Given this list of marker genes Cftr, Slc35d3, Nutf2, Ubr5, Ptpn22, Abcc8, Pmaip1, Erbb2, Gper1, Trpc1, Kif20b, Casr, Cep120, Dynll1, Cct4, Nlgn2, Fbxw7, Tmed10, Tek, Cd38, Tgfb2, Tgfb3 (transforming growth factor, beta 3), Ang2, Tomt, Atg7 (NCBI Gene Id 74244), Prkn, Ffar2, Gja1, Kcnn4, Osbp, Tmem132a, Cnst, Hnf1a (HNF1 homeobox A), Ppard, Sfn, Cdc42 (cell division cycle 42), Prkd1, Plk3, Rbm22, Ucn3, Golph3l, Hif1a, Emd, Cct2, Fto, Ice1 (interactor of little elongation complex ELL subunit 1), Adcy8, Commd1 (COMM domain containing 1), Adam9 (NCBI Gene Id 11502), Ptpn23, Il13, Glud1, Cd2ap, Prkaca, Exph5, Fga, Plcb1, Bag3, Fyn, Trh, Ghrl, Mmp13, Oaz2, Lep, Pfkfb2, Gsk3a, Tlr2, Doc2b, Pard6a, Ptbp1, Pcm1, Ipo5, Cdk5r1, Gck (NCBI Gene Id 14624), Oga, Trpa1, Vamp8, Dkc1, Sirt3, Cd81, Akap5, Nr1h4, Efcab7, Bad, Hras, Ppm1a, Snap25, Frmd4a, C2cd2l (NCBI Gene Id 71764), Pgrmc1, Camk2n1, Mcu, Pfkm, Nnat, Ran, Nutf2-ps1, Camk4, Vps28, Prkce, Bglap2, Glul, Itgam, Sh3glb1, Sec24a, Pak1, Glp1r, Vsnl1 (NCBI Gene Id 26950), Slc30a8, Atp2c1, Pdcd5, Tgfb1 (NCBI Gene Id 21803), Cask, Prpf4b, C1qtnf3, Mief1, Ifng (NCBI Gene Id 15978), Aacs, Coro2b (NCBI Gene Id 235431), Nkx6-1, Tcf7l2, Mief2, App, Prkcb, Acsl3, Ccl2, Sox4, Ptpn5, Isl1, Ang5, Chp1, Slc51b, Cct3, Or51e2, Myo1c, Lrrc8a, Gip, Dctn1, Rab29, Rab34, Orai1, Wls, Trpm2, Nr0b2, Pdcd5-ps, Hnrnpm, Apbb3, Anp32b, Tmem30a, Anxa7, Dnm1l, Mdm2, Rac1, Rufy3, Xpo4, Acsl4, Gpr27, Mavs, Gna11, C1qtnf12, Sybu, Ptger4, Atp13a2, Arpc2, Prkcq, Cct8, Edem2, Fgg, Hcfc1 (host cell factor C1), Arf1, Jup, Prkaa1, F2, Pcsk1, Serp1, Ywhae, Hyal2, Gpr68, Stom, Dmap1, Ankrd1, Zdhhc2, Prkcz, Psmd9, Myh9, Cenpj, Trpm4, Cacnb3, Vegfc, Mapk1, Flna, Ep300, Oaz3, Cct5, Cep131, Tomm7, Psen1, Tlr4, Abat, Pik3r2, Rph3al, Tmed10-ps, Rack1, Ier3ip1 (immediate early response 3 interacting protein 1), Abcg1, Gnas, Mapk14, Ffar1, Rfx6, Sytl4, Malrd1, Ang4, Stim1, Ank3, Gsk3b, Pdx1, Ppp3cb, Trim28, Camk1, Rapgef4, Ppia, Cep295, Tm9sf4 (NCBI Gene Id 99237), Gipr, Ppid, Shh, Myom1, Tent2, Pcnt, Chrm3, Hcls1, Agt, Oxct1, Ttn, Fgb, Tpr, Tnf, Lrp1, Bbc3, Tenm1, Ergic3, Cct6a, Ect2, Oaz1, Cep135, Pdcd10, Cdh1, Wrap53, A1cf, Prr5l, Apoe, Asph, Itpr1, Lepr, Ptgs2, Ang6, Wipf1, Tardbp, Cib1, Gpr39, Tcaf1, Mff, Tm7sf3, Gpld1, Arrb1, Hpca, Unc13b, Uaca, Stx4a, Mlxipl, Mtcl1, Lrp2, Ctdspl2, Hcar2, Hspa1l, Zpr1, Cct7, Baiap3, Arhgef5, Sirt1, Hsp90aa1, Nmu, Xbp1, Adcy10, Sirt6, Il1a, Kif5b, Vamp2, Adora2a, Myh10, F2rl1, Kif3a, Chp2, Ano1, Tomm70a, Sorl1, Cdk1, Tmem97, Cep290, Rbp4, Jak2, Ptp4a3, Trem2, Gnaq, F2rl2, Zc3h12a, Itgb1bp1, Mpc2, Trpm5, Pparg, Zfand1, Igf1, Cacna1c, Brca1, Sec16b (NCBI Gene Id 89867), Zfp384, Bcap31, Tsg101, Edem1, Ripor1, Ins2, Capn10, Irs2, Cdk5 (cyclin dependent kinase 5), Hsp90ab1, Cacna1d, Il6, Tunar, Crh, P2rx7, Fis1, Prnp, Cln3, Pck2, Src, Apbb1, Grin2a, Golph3, Blk, Bsg, Akt2, Actr3 (NCBI Gene Id 74117), Zic1, Prkcd, Gas6, Rapgef3, Smo, B3gat3, Chrm1, Nadk, Vps35, Eif3e, Kcnb1, Tmem30b, Gli3, Hdac3, Arf6, Myo18a, Gcg, Slc2a2, Tnfrsf1a, Myrip, Ncoa6, C2cd5 (NCBI Gene Id 77314), Ang, Pla2g6, Gprc6a, Ins1, Egfr, Pik3r1, Nr1h2, Pdzk1, Tcp1, Cemip, Prkar1a, here is a description of the gene set: studied in species Mus musculus Any process that activates or increases the frequency, rate or extent of establishment of protein localization. Mouse Gene Set: GOBP_POSITIVE_REGULATION_OF_ESTABLISHMENT_OF_PROTEIN_LOCALIZATION